Given this list of marker genes DYNC1LI1, DYNLRB1, DYNC2H1, TUBB6, TUBA1C, RAB7B, DYNLL2, TUBB4A, TUBB4B, DCTN2, DCTN5, DYNC1I2, DYNLL1, OSBPL1A, TUBA1B, DCTN1, TUBB2A (NCBI Gene Id 92919), TUBA3D, DYNLT3, ACTR10, TUBB1, TUBA3E, ACTR1A, DYNC1LI2, DCTN6, DYNLRB2, TUBA1A, TUBA4A, TUBB, DCTN3, TUBA3C, ACTR1B, DYNC1I1, DYNLT1, DCTN4, DYNC1H1, TUBB3, TUBB8, TUBB2B, RILP, TUBA8, RAB7A, DYNC2LI1, here is a description of the gene set: Human Gene Set: KEGG_MEDICUS_REFERENCE_RAB7_REGULATED_MICROTUBULE_MINUS_END_DIRECTED_TRANSPORT studied in species Homo sapiens Pathway Definition from KEGG: RAB7 == RILP == OSBPL1A == (DYNC+DYNL+DCTN+ACTR1+ACTR10) == (TUBA+TUBB) Rab7-regulated microtubule minus-end directed transport. Pathway ID: N01295. Pathway type: Reference. Pathway class: nt06125 Membrane trafficking (bacteria).